Given this list of marker genes SYNGR3, CLEC2L, TUBBP5, ENSG00000271776, RAB37 (RAB37, member RAS oncogene family), RPL31P54, CHRNB3 (NCBI Gene Id 1142), P2RX3, RN7SL164P, B4GALNT1, DDX50P2, AKAIN1, CHRNA6, SYT2, POU4F2, IL1RL2, OPN4, SLC17A6-DT, C4orf50, POU4F1, LINC01014 (long intergenic non-protein coding RNA 1014), LINC02505, LINC01606, MTUS2-AS2, PRPH, SLC17A6 (solute carrier family 17 member 6), IRX4, LGI3, FNDC9, C1QTNF1-AS1, SYT5, TFAP2D, GPR139, LINC02118, CEND1, OBI1-AS1, LRRC73, LINC02217, NRN1, EOMES, LINC00348, KIF5A, TMEM74, TMEM163, GRASLND, GPR149, INA, GAP43, ISLR2, IL12A, here is a description of the gene set: The gene expression program underlying the specification of human cell types is of fundamental interest. The study authors generated human cell atlases of gene expression and chromatin accessibility in fetal tissues. For gene expression, the study authors applied three-level combinatorial indexing to >110 samples representing 15 organs, ultimately profiling ~4 million single cells. The study authors leveraged the literature and other atlases to identify and annotate hundreds of cell types and subtypes, both within and across tissues. Our analyses focused on organ-specific specializations of broadly distributed cell types (such as blood, endothelial, and epithelial), sites of fetal erythropoiesis (which notably included the adrenal gland), and integration with mouse developmental atlases (such as conserved specification of blood cells). These data represent a rich resource for the exploration of in vivo human gene expression in diverse tissues and cell types. Human Gene Set: DESCARTES_FETAL_EYE_GANGLION_CELLS Marker genes curated from the annotated cluster as represented in the Descartes Human Gene Expression During Development database. from publication Cao J, O'Day DR, Pliner HA, Kingsley PD, Deng M, Daza RM, Zager MA, Aldinger KA, Blecher-Gonen R, Zhang F, Spielmann M, Palis J, Doherty D, Steemers FJ, Glass IA, Trapnell C, Shendure J (PMID 33184181) studied in species Homo sapiens